Given this list of marker genes EZH2, ERI1, TCF4, CDC42BPB, HDAC4, HEPHL1, ITPR1, LZTFL1, PEX7, PRMT7, FAT4, DCHS1, PIGS, ZNF407, RSPRY1, PHYH, here is a description of the gene set: species: Homo sapiens Human Gene Set: HP_SHORT_FOURTH_METATARSAL Short fourth metatarsal bone. Short fourth metatarsal